Given this list of marker genes EZR, PIK3CB, GPR3, PIK3CG, S1PR5, SPHK1, RAC1 (Rac family small GTPase 1), SPHK2, SPNS2, S1PR2, GPR6, S1PR1, S1PR4, S1PR3, AKT1, MFSD2B, here is a description of the gene set: A G protein-coupled receptor signaling pathway initiated by sphingosine-1-phosphate binding to its receptor on the surface of a cell, and ending with the regulation of a downstream cellular process, e.g. transcription. Human Gene Set: GOBP_SPHINGOSINE_1_PHOSPHATE_RECEPTOR_SIGNALING_PATHWAY species: Homo sapiens